Given this list of marker genes SIRT1, MIR132, MIR204, MIR766, PIBF1, here is a description of the gene set: Human Gene Set: GOBP_NEGATIVE_REGULATION_OF_PROSTAGLANDIN_BIOSYNTHETIC_PROCESS species: Homo sapiens Any process that stops, prevents, or reduces the frequency, rate or extent of the chemical reactions and pathways resulting in the formation of prostaglandin.